Given this list of marker genes OAT, SLC6A8, CKB, GATM, GAMT, here is a description of the gene set: Creatine pathway Human Gene Set: WP_CREATINE_PATHWAY studied in species Homo sapiens